The following is a description of a gene set: Genes down-regulated in macrophages treated by IL6 for 400min: wildtype versus SOCS3. species: Homo sapiens from publication Lang R, Pauleau AL, Parganas E, Takahashi Y, Mages J, Ihle JN, Rutschman R, Murray PJ (PMID 12754506) Human Gene Set: GSE411_WT_VS_SOCS3_KO_MACROPHAGE_IL6_STIM_400MIN_DN Effects of SOCS3 on the transcriptional response of bone marrow-derived macrophages to IL-6. Fetal liver cells from SOCS3+/+ or SOCS3-/- embryos were used to reconstitute recipient mice. Donor derived bone marrow from these mice was differentiated to macrophages. Macrophages were either unstimulated, or stimulated for 100 or 400 minutes with 10 ng/ml IL-6., and this is the list of marker genes: CHST14, HAAO, PIP5K1B, PTK2B, L3MBTL2, GPD1L, SPIC (Spi-C transcription factor), WDR53, GPN1, PCIF1, MCAT, DDX46, CHMP6, MSL1, MMD, ZNF493, STMN3, MTAP, BRF2, LRATD2, MTX3, CCDC66, ZNF639, MTRF1L, CCDC85B, PTCD3 (NCBI Gene Id 55037), CABLES2, CD46, PCSK4, MAPK11, ARRDC3, PEX2, CNR2, CTPS2, TUSC2, TMEM86A, ZNF746, CTSS, TREML2, AMPD3, ZSCAN26, RNF181, CMTM7, IFT70A, SSBP2, AEN, TRMT44, TBCC, ABCF3 (ATP binding cassette subfamily F member 3), EXOSC10, TRMT6, POLR3H, ZNF398, GPATCH2L, SLC35A4, ZNF770, UPF3B, MAJIN, HTATSF1, JAGN1, NR2C2AP, PWP2, MCL1, NAPG, TIGAR, CERS4, MTURN, GALNT4, MAP3K5, GPAM, AP4B1, SETD6, LRIG1, TRMT61A, GEMIN4, JRK, ACBD3, AP5B1, STARD5, YIF1A, PRRC1, ELMOD2, ITPR3, AMER1, LIPT1, ZFP90, DTX4, CALR, DNAJA3, SDC4, ABCA1, FBXO46, CCDC71, PSKH1, PJA2 (praja ring finger ubiquitin ligase 2), LPAR6, HSH2D, BICRAL, FOXO1, TMEM177, RAPGEF6, YJU2B, OBI1, HDDC3, DSTYK, PPP1R3F, MIGA2, PDE2A, SLCO5A1, CD40, HDAC2, ARHGAP18, GRAP2, ZKSCAN8, GDPGP1, HLA-DOB, MED17 (mediator complex subunit 17), ZNF383, RNF130, PLIN2, GAD1, MOGS, PBLD, GLT8D1, SNAPC3, NRAS, PDCL, ZFP41, CRYBG3, ZNF266 (NCBI Gene Id 10781), OXSM, HGS (hepatocyte growth factor-regulated tyrosine kinase substrate), PRSS12 (serine protease 12), FAF2, DCAF13, CAST, SMAD1, MIEF1, MYO9A, TUT1, LYRM9, TMEM181, CPT2, ZNF48, TGDS, ZBTB33, ZC3H7B, YTHDF2, CEP70, SLC12A6, COQ2, MRPL39, LPCAT2, KYAT1 (kynurenine aminotransferase 1), HCK, C1orf174, CLCF1, IFI27, FOXRED2, GGA2, GLCE, PSTK, SMU1, TNN, MTMR10, SMUG1 (NCBI Gene Id 23583), MAST4, DNAAF2, DPH7, PARS2, C2orf42, MAPK9 (mitogen-activated protein kinase 9), ZMAT2, DNAJB14, MARVELD2, HNRNPF, GLCCI1, ZNF784, KIAA1143, PPM1B, SRPK3 (SRSF protein kinase 3), FANCE, BBS4, STARD8, DGCR2, PPT1, SLK, MAF1 (MAF1 homolog, negative regulator of RNA polymerase III), RRP8, FCER2, ZNF229, SGSH, LAMB3, RBBP5, URI1, COPS7B, PCM1, FEM1A, MAPK3, UNKL (NCBI Gene Id 65259)